The following is a description of a gene set: species: Mus musculus Reactome Pathway: Pregnenolone biosynthesis part of: Metabolism of steroid hormones This event has been computationally inferred from an event that has been demonstrated in another species.<p>The inference is based on the homology mapping from PANTHER. Briefly, reactions for which all involved PhysicalEntities (in input, output and catalyst) have a mapped orthologue/paralogue (for complexes at least 75% of components must have a mapping) are inferred to the other species. electronically inferred by orthology from the curated human pathway, and this is the list of marker genes: Fdx1, Stard3, Tspo, Stard3nl, Tspoap1, Fdxr, Fdx2, Akr1b1